Given this list of marker genes Myc, Jun, Gpr68, Apcs, Il34, Fes, Csf1, Ctnnbip1, Cdk6, Bmyc, Zfp36l1, Cd74, Acin1 (NCBI Gene Id 97920), Zbtb46, Inpp5d, Hoxa7, Foxp1, Cd4, Dcstamp, here is a description of the gene set: Any process that modulates the frequency, rate or extent of monocyte differentiation. Mouse Gene Set: GOBP_REGULATION_OF_MONOCYTE_DIFFERENTIATION species: Mus musculus